Given this list of marker genes GABARAPL1, SYT13, CCNB2, DEPDC1B, IL18, LRP1, ISG20, HEMGN, TCF7, IFTAP, TICRR, KNSTRN, DNTT, CENPE, PMM1, SYK, NSD2, SPO11, CDC20, TXN, CKS2, IFNGR1, DHRS3, DAB2IP, SNAP91, CHCHD6, ARPP21, CDCA8, DESI1, LPCAT2, ANGPTL2, SPC25, SCN2B, INMT, OCIAD2, GLCCI1, RRM2, LIG1, ENDOU (NCBI Gene Id 8909), GTF2H4, HLA-DQA1, ADA, YBX3, IGKC, CDK2AP1, FCER1G, SAP30, MAD2L1, FKBP5, TUBA1B, DUT, MIER1, FABP5, ASRGL1, CLK3, CXCR4, PSMB11, DGKE, RMND5A (required for meiotic nuclear division 5 homolog A), HS6ST1, LONRF1, TMEM107, HMGB2, ASPM, FEN1, NFATC3, TUBE1, PSAP, ETS2, DYNLT1 (dynein light chain Tctex-type 1), CD83, TBATA, MED13, CD8A, KIF2C, FOXN1, KRT18, PLTP, ZNF704, CXCL12, SLC6A8, MMP2, CRIP2, IGSF8, MORC1 (NCBI Gene Id 27136), NUF2, FGR, TF, LY75, SGO1, BID, CSF1R, TSC22D1, CENPF, DSTN, BANK1, C12orf75, TP53INP2, NTN1, PLEKHB1, CDC45, RPA3, HPGD, PTPN13, SFRP1, E2F7, TNC, ZNF503, ASF1B, MKI67, PRC1, RAPGEF3, BUB1B, ADAM12, CYB5A, LIG4, MNS1 (meiosis specific nuclear structural 1), C3, CDCA5, EPB41L3, DNAJC6, CSTB, KPNA2, SMARCC2, CDC25C, TLCD3A, POU6F1, PBK, CD93, PKP1, KIF11, SLC6A19, AURKA, CERK, SPC24, CKAP2L, AQP11, STMN1, HMGB3, KIF18B, CKAP2, TMEM140, DMRT2, FBXL12, MAGED1, IL7, ANXA2, EXO1, ALDH7A1, WDR91, SGPL1 (NCBI Gene Id 8879), MXD3, STOM, XRCC6, SYTL3, TMEM151B, PRSS16, DIRAS2, TENM4, CTSH, SKA1, NCK2, TCF4, ANKRD50, MPP1, CTSV, RAG1 (NCBI Gene Id 5896), TMEM51, HLA-DRB1, PAPSS2, GMPR, HMMR, RAG2, WNT4, AGFG2, CAMKK1, CDKN2C, KIF20A, GFI1, SSBP2, RPS27L (NCBI Gene Id 51065), NIM1K, OSBPL1A, CLIC4, ADGRG1, LDHB, MREG, CDC6, HEY1, RCBTB2 (RCC1 and BTB domain containing protein 2), SH2D1A, IGHM, WEE1, COL4A1, SMARCD2, SPATS2 (NCBI Gene Id 65244), MR1, PCLAF, NPNT, here is a description of the gene set: from publication Borjesson DL, Kobayashi SD, Whitney AR, Voyich JM, Argue CM, Deleo FR (PMID 15879137) species: Homo sapiens Genes up-regulated in polymorphonuclear leukocytes (9h): treated by heat killed HC60 cell (promyelocytic leukemia) lysate versus A. phagocytophilum infection. Polymorphonuclear leukocytes (PMNs) were obtained from healthy individuals in accordance with protocols approved by the Institutional Review Board for Human Subjects at the University of Minnesota and the National Institute of Allergy and Infectious Diseases. PMNs (107) were combined on ice with live S. aureus (108) or with live or heat-killed A. phagocytophilum (bacteria isolated from 5x106 infected HL60 cells for a ratio of 1 infected HL60 cell: 2 PMNs, ~ 5-20 A. phagocytophilum: PMN) in wells of a 12-well tissue culture plate (pre-coated with 20% autologous normal human serum). Unstimulated control assays received either buffer (for S. aureus comparisons) or clarified HL60 lysate (for A. phagocytophilum comparisons). Plates were centrifuged at 350 x g for 8 min at 4oC to synchronize phagocytosis and incubated at 37 deg. C in a CO2 incubator for the indicated times. At the indicated times, tissue culture medium was aspirated from the plate and PMNs were lysed directly with RLT buffer (Qiagen, Valencia, CA). Purification of PMN RNA and subsequent preparation of labeled cRNA target was performed as described in Methods. Labeling of samples, hybridization of cRNA with HU133A oligonucleotide arrays (Affymetrix, Santa Clara, CA), and scanning were performed according to standard Affymetrix protocols ( http://www.affymetrix.com/pdf/expression_manual.pdf ). Experiments were performed in triplicate, using PMNs from three healthy individuals for each treatment. Human Gene Set: GSE2405_HEAT_KILLED_LYSATE_VS_LIVE_A_PHAGOCYTOPHILUM_STIM_NEUTROPHIL_9H_UP